The following is a description of a gene set: Mouse Gene Set: MIR_6972_5P species: Mus musculus from publication Chen Y, Wang X (PMID 31504780) Genes predicted to be targets of miRBase v22 microRNA mmu_miR_6972_5p in miRDB v6.0 with MirTarget v4 prediction scores > 80 (high confidence targets)., and this is the list of marker genes: Mtcl2, Coprs (coordinator of PRMT5, differentiation stimulator), Aak1, Epsti1, Trp53inp1, Galnt10, Gzmd, Sh3pxd2b, Cacul1, Phldb2, Phf21a, Aifm3, Xcr1, Satb2, Ccnh, Nfu1, Gzmg, Dlx3, Card11, Syp, Gramd2a, Hhipl2, Cpne6 (NCBI Gene Id 12891), Plxnc1 (plexin C1), Scube1, Mgat5b, Itprip, Slc1a1, Pla2g5, Maml1, Fam20b, Cuedc1 (NCBI Gene Id 70393), Nhsl2, Madd, Pnck, Spry2, Shisa6, Bcat1, Klra17, Ccdc177, Gzme, Ldlrad3, Selp, Trpc5os, Sypl2, Pnkd, Matn1, Lmnb2, Pcyt1a, Frat2, Farp2, Dtnb, Krt5, Adarb1 (adenosine deaminase, RNA-specific, B1), Tnfrsf11a, Gzmf, Bcl7a, Tcim, Slc13a3, Fhl1, Ywhab, Arpc5, Sumo2, Ndst1, Pars2, Zbtb2, Dpm2 (NCBI Gene Id 99419), Usp18, Gzmn, Bcl9l, Fzd4, Cry2, Mmp15, Nfia, Rgs16, Scimp, Tmem164, Osm, St6galnac6, Slc25a37, Pakap, B4galt1, Rfx4, Tmem62, Sap130, Celf5, Cntn2, Faim2, Zfand5, Tox3, Adrb3, Fkbp1a, Atxn7l2, Kremen1, Alpk1, Borcs5, Tubb5